Given this list of marker genes FCRL5, CENPM, ZNG1A, FASTKD1, RPN2 (ribophorin II), SLC35F2 (NCBI Gene Id 79593), SEC24A, TNFRSF17, COL4A4, PERP, DERL2, MOXD1, SSPN, SRPRB, FICD, TOP6BL, POU2AF1, TXNDC11, GINS1, UGT2B17, DERL3, RASGRP3, SPATS2, SLC2A5, MRPS14, GGH, DCPS, XBP1, ERLEC1, PTTG1, IGKV4-1, SLC38A5, EFHC1 (EF-hand domain containing 1), PARM1, IGLJ3, GMPPB (GDP-mannose pyrophosphorylase B), H4C3, HIBCH, TPD52, SUB1, UGT2B15, SEL1L3, FKBP14, SELENOS, IGLV1-44, PPIB, ACOXL, OSBPL10, RAB30 (NCBI Gene Id 27314), MANF, GARS1, IGKV1D-13, UBE2J1, PBK, MCEE, TLR10, CAV1, NUF2, HSPD1, CRYBA4, SLC25A4, NT5DC2, UQCRH, BUB1, B4GALT3 (NCBI Gene Id 8703), DLGAP5, CXXC5, GLDC, SRP54, ARHGAP42, EAF2, E2F8, NLRP14, VOPP1, CDC6 (NCBI Gene Id 990), BUB1B, DENND5B, SNRPG, CDK1, IGKV3-20, IGLV6-57, CENPS, SPAG5, CD180, TEX9, PRDX4, ALG5, PGM3 (NCBI Gene Id 5238), CENPI, DOCK3, UMAD1, CXCR3, STIL, CCNB1, CHAC2, SDC1, NARS2, OSTC, SPO11, KLHL14 (kelch like family member 14), GEN1, SUCLA2, CFAP263, SLC44A1, PCLAF, NOC3L, STK19, NCAPG, IGHM (immunoglobulin heavy constant mu), CD38, GNG7, CCNB2, TNFRSF13B, SLC16A14, RNF121, PRDM15, RRM2, MZB1, CLPTM1L, COBLL1, FGD5-AS1, ITM2C, ZNF225-AS1, SSR3, MYDGF, IGLV3-19, LIG4, SLAMF7, PHB1, TRAM2, PDIA5, SP140, KDELR2, LMAN1, CDC20, OIP5, MAN1A1, GLCCI1, ACADM, GPRC5D, COL24A1, SDF2L1, ATP5PF, GUSBP11 (GUSB pseudogene 11), TMEM19, PHGDH, FKBP3, PHB1P19, CDKN3, PNOC, TRIP13, IGLL3P, ZBTB32, CHEK1, ALG14, ZCCHC9, MKI67, SLC7A11, GALK2, SCG3 (NCBI Gene Id 29106), CRELD2, SLC35F5, CEP128, GADD45GIP1, EFCAB11, C3orf52, SEC11C, MIR155HG, SHCBP1, KIF4A, ENSG00000291006, POLR3G, FAIM, RNASEH2C, TXNDC15, SEC61B, FAM174A, IGKC, BLNK, BHLHE41, TIGD6, HMMR, MYL6B, HSP90B1, ARL1, LAX1, GPT2, DNAJB11, GPLD1, JCHAIN, MACIR, here is a description of the gene set: species: Homo sapiens Human Gene Set: GSE29614_DAY3_VS_DAY7_TIV_FLU_VACCINE_PBMC_DN Genes down-regulated in comparison of peripheral blood mononuclear cells (PBMC) from TIV influenza vaccinee at day 3 post-vaccination versus those at day 7 post-vaccination. from publication Nakaya HI, Wrammert J, Lee EK, Racioppi L, Marie-Kunze S, Haining WN, Means AR, Kasturi SP, Khan N, Li GM, McCausland M, Kanchan V, Kokko KE, Li S, Elbein R, Mehta AK, Aderem A, Subbarao K, Ahmed R, Pulendran B (PMID 21743478) Systems vaccinology has emerged as an interdisciplinary field that combines systems wide measurements and network and predictive modeling applied to vaccinology. Here we used the systems vaccinology approach to study the molecular mechanisms underlying the innate responses to the trivalent inactivated influenza (TIV) and live attenuated influenza (LAIV) vaccination in humans, and to identify early gene signatures that predict the magnitude of the antibody responses to influenza vaccination.